The following is a description of a gene set: species: Mus musculus Mouse Gene Set: GOMF_RECEPTOR_ANTAGONIST_ACTIVITY The activity of a gene product that interacts with a receptor to decrease the ability of the receptor agonist to bind and activate the receptor., and this is the list of marker genes: Adh7, Wfikkn2, Mtrnr2l7, Lrpap1, Dkk4, Ccl5, Fst, Wfikkn1, Angpt2, Dkk1, Dkkl1, Dkk2, Il1rn, Dkk3, Igsf1